Given this list of marker genes LAPTM4B, SNX4, EHMT2, EPHB2, RAB3GAP1, SCARB2, C9orf72, FLCN, SNX30, IFT88, TREX1, ATM, EFNB1, RAB3GAP2, TBC1D12 (TBC1 domain family member 12), SCFD1, RAB5A, IRGM, RNF5, SH3GLB1, FEZ2, BECN1, SNX18, PIKFYVE, PINK1, MOAP1, SEC22B, PIP4K2C, TFEB, LRRK2 (leucine rich repeat kinase 2), ATG2A, TMEM39A, MTM1, LRSAM1, RALB, WIPI1, SMCR8, TBC1D14, TRIM32, FEZ1, UBQLN2, SNX7, WDR45, PHF23, MTOR, IFT20, PIP4K2B, TMEM106B, CHEK2 (NCBI Gene Id 11200), PIP4K2A, RNF186, ULK1, PPP3CB, GRN, MTMR3, ELAPOR1, FNIP1, NUPR1, MCOLN1, RAB1B, ANXA2, here is a description of the gene set: Any process that modulates the frequency, rate or extent of a process involved in the formation, arrangement of constituent parts, or disassembly of a vacuole. studied in species Homo sapiens Human Gene Set: GOBP_REGULATION_OF_VACUOLE_ORGANIZATION